The following is a description of a gene set: Genes down-regulated in peripheral blood mononuclear cell post-vaccination vs pre-vaccination in adults (18-40) after exposure to YF-Vax or APSV Wetvax (identical responses), time point anyD. Comment: Significantly Modulated Genes Common to Vaccinia and Yellow Fever Vaccination Gene expression in human peripheral blood mononuclear cells was systematically evaluated following smallpox and yellow fever vaccination, and naturally occurring upper respiratory infection (URI). All three infections were characterized by the induction of many interferon stimulated genes, as well as enhanced expression of genes involved in proteolysis and antigen presentation. Vaccinia infection was also characterized by a distinct expression signature composed of up-regulation of monocyte response genes, with repression of genes expressed by B and T-cells. In contrast, the yellow fever host response was characterized by a suppression of ribosomal and translation factors, distinguishing this infection from vaccinia and URI. No significant URI-specific signature was observed, perhaps reflecting greater heterogeneity in the study population and etiological agents. Taken together, these data suggest that specific host gene expression signatures may be identified that distinguish one or a small number of virus agents. Human Gene Set: SCHERER_PBMC_YF_VAX_OR_APSV_WETVAX_AGE_18_40YO_JOINT_TO_VACCINIA_AND_YELLOW_FEVER_DN species: Homo sapiens from publication Scherer CA, Magness CL, Steiger KV, Poitinger ND, Caputo CM, Miner DG, Winokur PL, Klinzman D, McKee J, Pilar C, Ward PA, Gillham MH, Haulman NJ, Stapleton JT, Iadonato SP (PMID 17651872), and this is the list of marker genes: ZAP70, C12orf57, TSPAN4, CBX7, RPL9, TCF3, CD3D, TMC6, ARL4C, RPS21, RPS3A, KLRB1, RPS10, RPL13, KIF22, LTB, RPL10A, LDHB, ICAM3, RPS15A, RPL23A, EEF1B2, B4GALT3